Given this list of marker genes Fstl1, Col3a1, Lum, Serpina5, Pglyrp1, Vtn, Stc1, Vav2, App, Ccnd2, Fgfr1, Vcan, Spp1, Tnfrsf21, Prg2, Col5a2, Slco2a1, Kcnj8, Apoh, Cxcl5, Ptk2, Olr1, Msx1, Jag2, Vegfa, Lpl, Thbd, Itgav, Pf4, S100a4, Postn, Timp1, Nrp1, Pdgfa, Jag1, Lrpap1, here is a description of the gene set: from publication Howe DG, Blake JA, Bradford YM, Bult CJ, Calvi BR, Engel SR, Kadin JA, Kaufman TC, Kishore R, Laulederkind SJF, Lewis SE, Moxon SAT, Richardson JE, Smith C (PMID 30224793) Mouse Gene Set: HALLMARK_ANGIOGENESIS studied in species Mus musculus Mouse genes annotated to HALLMARK_ANGIOGENESIS based on orthology mappings provided by the Alliance Genome Consortium